Given this list of marker genes NR3C1, PRKACA (NCBI Gene Id 5566), KDM1A, BRAF, CDH23, PDE11A, USP8, PRKAR1A, XYLT1, H4C5, GNAS, USP48, ARMC5, TP53, ATRX, here is a description of the gene set: studied in species Homo sapiens Human Gene Set: HP_MOON_FACIES A rounded, puffy face with fat deposits in the temporal fossa and cheeks, a double chin. Moon facies